The following is a description of a gene set: from publication Tabula Muris Consortium (PMID 32669714) Mouse Gene Set: TABULA_MURIS_SENIS_LIMB_MUSCLE_SCHWANN_CELL_AGEING species: Mus musculus, and this is the list of marker genes: Tcf25, Scaf11, Rdx, Apod, Plac9, Hp1bp3 (NCBI Gene Id 15441), Mdh1, Oat, Srrm2, B2m (NCBI Gene Id 12010), Tln1 (NCBI Gene Id 21894)